The following is a description of a gene set: Lacto series sphingolipid metabolism studied in species Homo sapiens Human Gene Set: WP_LACTO_SERIES_SPHINGOLIPID_METABOLISM, and this is the list of marker genes: B3GNT5, FUT2 (NCBI Gene Id 93237), B3GALT1, FUT3 (fucosyltransferase 3 (Lewis blood group)), B3GALT2, FUT1